Given this list of marker genes PSMF1, SMG1P3, AFF4, RAD17, TTC1, ASXL1, ANKRD40, TACO1, DPY19L4, AHCYL2 (adenosylhomocysteinase like 2), ATAD3A, RITA1, COLGALT1, MBD6 (NCBI Gene Id 114785), PCGF3-AS1, KLHL20, AGBL5, TUBA1A, USPL1, ITGB1BP1, TIMM29, ITGA7, CARS2, PTP4A2 (protein tyrosine phosphatase 4A2), PNMA2, ZNF629, SIN3B, TMEM181 (NCBI Gene Id 57583), PRDX1, VPS72, HNRNPK, GSE1, CCNT1, WASF2, ADAM15, FBH1 (NCBI Gene Id 84893), GRK6, LAMTOR5, MYORG, LINC02361, EDC4, KNTC1, PFKL, SCAF1, SENP6, ULBP1, CDC42EP4, CECR2 (NCBI Gene Id 27443), SMARCD2, SNORD54, NSA2, FRA10AC1, ARHGAP28, RPS26, ZFP36, TOB1, ADD2, SMAD2, BLOC1S1, CAP1, MED23, SYCE2, INO80C, B4GALT5, SMIM14-DT, PINX1-DT, CBX2, FZR1, LAMP1, GABARAPL1, C19orf38, GPX1, MCEE, NME1, HNRNPUL1, HUS1, REXO4, POLDIP3, SNHG7, LINC02768, DMAP1, MARK1, KCNIP2, VIM, ATAD2, DDX3X, CATSPERG, MIPEP, RBM28, DENND3-AS1, TM2D1, INVS, ZKSCAN2, SUGCT, TUBA1C, GNAL, CPT1C, MRPS31, OSER1, SNHG22, KCTD9, NOP16, LTBP4, FGD6, TRIP4, IQCH, GATA6, ETV4, WNT10B, ERCC5, TUBB2A, ZFYVE1, GLI3 (NCBI Gene Id 2737), UTP3, LINC02960, DTWD1, TBC1D13, CPOX, STX18, PMP22, NCOA3, GNG12-AS1, CHCT1, SOX8, TTC4, TOP6BL, COMTD1, DYNC2I2, TRDMT1, ZFP28, CMSS1, KCTD5, VMAC, PPP1R35, CDK4, CEP112 (NCBI Gene Id 201134), PBX3, NFE2L1-DT, PDCD6-DT, MZT2B, BHLHE40, RACGAP1, CCNI, EXD2, NOL9, EIF4A3 (NCBI Gene Id 9775), KLC1, ASAP3, HEATR5A-DT, SAE1, SLC25A6, SNORA16A, TMED1, RANBP1, KCTD7, CEP120, CIC, AP3M2, HNRNPD-DT, CD2AP-DT, PAFAH2, ALDOA, ACOX1, ENO3, FEM1B, MALAT1, NSL1, PPP2R5B, KANSL3, VDAC3, MRPL39, LMNB1-DT, CLIC4, MZT2A, STAT6 (signal transducer and activator of transcription 6), TYMS, KIAA1586, BRF2, GANC, GNAI3, AP4M1, STARD3NL, ZMIZ1-AS1, HSPE1, ASH2L, WIZ, BRD2, SPTAN1, CTNNB1, FAAP20, CFL1, VPS25, RPL41, RPL37A, DST-AS1, PSMD9, MACIR, GSPT1, RNF32, RPL37, IMMT, MAP3K14-AS1 (MAP3K14 antisense RNA 1), PRKAA1, GEMIN5, COX16, MRPL16, AK6, RBSN, FXYD5, SEC31A, CCDC88A, UBE2L3, RPL29 (ribosomal protein L29), DPP8, PHF12, GAS5, ZNF892 (zinc finger protein 892), GSX1, NUP155, SDHAF3, BECN1, HM13, SNAP29, CDCA2, CPSF3, RETREG2, USP30, ZNF165, FAM200B, RPLP2, SPATA33, CHFR-DT, SOS1, ATP6V1G2, RABGEF1, NAA80, RHOC, DNAJC25-GNG10, UQCC6, MAP3K21, LRP6, RAC1, POLR3H, TRIM46, AMN1 (NCBI Gene Id 196394), MPHOSPH10 (NCBI Gene Id 10199), TAGLN2 (NCBI Gene Id 8407), PDXK, S100A4, EFNB3, MTND5P11, ABCC10, HEXIM2-AS1, GPRC5A, ATG13, PLD6, ZNF839, SLC27A4, KMT2A, NFE2L1, SERTAD3-AS1, GGNBP2, CALM2, NEURL2, LINC01275, LINC01547, GTF2H4, LINC00431, ERP44, GSTCD, USP32, TAS1R1, DDX46, LINC00662, FAM241B, ARPP19 (cAMP regulated phosphoprotein 19), PRPH, ICE1 (NCBI Gene Id 23379), IRF9, WDR13, GNB2, DST, YIPF2 (NCBI Gene Id 78992), SLC15A4, MAD2L2, GOLT1B, CNPPD1, CEROX1, TMEM104, C6orf141, TOB1-AS1, ZFP30, ANKRD28, ZNF213-AS1, BRMS1L, ZNF609, RECQL, KRT8, EML2, CDC42, TATDN3, FAAH, PIF1, EXOC2, SMG7-AS1, AJUBA-DT, AJUBA, STAT3, DCTN6, TNNT1, UBC, DDX54, ZMYM1, POLK, CCDC77, MTMR9, CTSA, MARCHF6, EFCAB14, PPP1R12A, RGS5, IL12A, ZNF205, ARHGAP45, LOH12CR2, APOM (apolipoprotein M), PHF5A, CDC42SE1, RNF32-DT, SCAP, TAMM41, HOXB3, GINS3, UBE2A, PICALM, PDCD6IP, THUMPD3-AS1, LRRFIP2, MAN2C1, STX16-NPEPL1, RUVBL1, RNU12, BBX, BMS1P4-AGAP5, ERBB3, DYNLT1, ATP5PD, ZFP28-DT, H2AC25, PAFAH1B2, MYL6, ZNF503, MECR, NDUFS3, MLH1, CELSR1, PI4KA, S100A2, RSRC2, TCTA, CERNA3, ATRIP, LINC02987, SYT7, USP45, MCF2L, TCF3, CCNL1, POFUT2, MTA2, KMT2D, MTHFD1, ACAA2, CACTIN, NUP62, FAM83E, EIF1 (eukaryotic translation initiation factor 1), PPP2CB, WEE2-AS1, ZNF585B, ZNF561, MIR4453HG, PKMYT1, YIF1B, SLC25A45, TLE2, PLEKHM1, C1orf159, ZNF391 (zinc finger protein 391), DCTN6-DT, FAM227B, PPP1R3E, FNTA, HCFC2, MICU1, UBE2Z, USP31, SGMS1, PEMT, CIMAP3, BCAT2, KBTBD4, MOB3A, IER5L-AS1, MIR6781, DCP1A, CREBL2, MRPL40, MRPL27, INTS14, WDR24, C17orf75, AGBL5-AS1, PLEKHG4B, KCTD10 (potassium channel tetramerization domain containing 10), DDX1, PIM1, RP2, SELENOH, ACO2, NUF2, SYNPO2, OTUD7B, RMI2, STX16, ANO8, SLBP, EPCIP-AS1, HSPE1-MOB4, CHRNB1, SSBP1, PDCD6, URM1, SDE2, RCOR1, SLC33A1, WDR11-DT, MTF2, ZNF354A, SPACA9, ENSG00000261398 (NCBI Gene Id 112268173), BANF1, RTN4, CCDC97, ZNF233, NDUFA11 (NCBI Gene Id 126328), LMF1, PEF1-AS1, PNPLA7, NAGK, SAMD4B, PIK3R1, DNAH2, GUSB, GABPB2, JPX, STARD4, ANKRD16, PRELID2, ZMYM6, DAB2IP, GOLM2, TRIM37, AFF4-DT, MRPL48, ZMPSTE24, MET, LARGE1, LMF2 (NCBI Gene Id 91289), SF3A3, RPS8, CA5BP1, NMNAT1, ENSG00000247416, RPL22, CAST, GOLGA3, ZNF503-AS2 (ZNF503 antisense RNA 2), MARCHF6-DT, KDM5C, DYRK1B, SMPD4, LRRC59, RHOA, PINX1, MC1R, WDR11, PANX1, LINC01409, ANP32B, TPT1-AS1, SCAPER, SERTAD3, FAR1, C12orf75, HARBI1, SNORD55, SMG8, MMUT, CLPTM1, KAT6B, BUD31, METTL2B, ST13, UBE2H, IZUMO4, RAD52, CPPED1, PPP1R18, ZNF561-AS1, CD2AP (NCBI Gene Id 25916), TMEM41A, CASC3, SLC25A53, ARL6IP1, ATP5MF-PTCD1, SELENOW, LINC02352, GBA1, CD9, TLCD3B, RPL38, PIPOX, SPRY4, DUS1L, VEZT, PKP2, RPL27, PDCD6P1, LZIC, PFN1, DLEU1, LGALS1, NDUFS7, PTGES3, TMEM87A, MBD2, RAB11A, SLC36A1 (solute carrier family 36 member 1), BPTF, NFKBIL1, ZNF76, SNRPE, DISC1, RPL37A-DT, ZNF581, HEXIM2, RPS20 (NCBI Gene Id 6224), RPS14, ZNF793, NOXA1, HSPB6, SH2B3 (SH2B adaptor protein 3), TAF3, CTNNA1, SVIL, DENR, CAPNS1, KDM5A, ADGRE5, SND1, CYP1A1, GLT8D2, SNHG11, INTS12, SYNC, PPT1, UCKL1, CEBPA, NME1-NME2, LRRC57, CSNK1D, SLC24A1, NHP2, INO80B, TRAF4, AGGF1, C1QL4 (NCBI Gene Id 338761), ZER1, HBS1L, GATA6-AS1, GABBR1, WDR31, MICAL3, PHF20, EIF2S3, XKR6, KCNH2, TPT1, SYK, SUZ12P1, EXD3, HYAL3, PPP2R3C, TMEM242, VARS1, FBXL5, VARS2, UBB, CSTPP1, ATF5, CDIP1, LRFN4, INO80B-WBP1, RRAGC-DT, DNAJC25, PPP1R14C, BBS1 (Bardet-Biedl syndrome 1), TMEM200B, CD2BP2, RBPJ, GINS1, ZNF181, TNFAIP8, FAM168A, MRPS31P5, NR2F1, PLIN3, DCLK1, ZBTB37, KLHDC9 (NCBI Gene Id 126823), COQ8B, DENND3, EXOSC3, RRP15, SNHG12, ZCCHC2, PBX3-DT, CERT1, AGA, SMG7, ATXN2L, C12orf76, SLC41A2, PCLAF, LNP1, CCNDBP1, PTPN21, WDR43, BIRC5, SLC39A3, MNT (NCBI Gene Id 4335), SH2D3A, TMEM222, RBAKDN, TBRG4, NCAPH2, NR2F6, MRPS31P4, GFM2, KPNB1, MAP2K2, DRG2, ADAP2, DPCD, DHDDS, PSIP1, AAGAB, TTC33, IPO4, EME1, CNIH3, KRTCAP2, PTPN18, CFAP298, PAK1IP1, CHFR, SMIM14, YJU2, BORCS5, SRCIN1, SVIL-AS1, RNU7-27P, KCNJ4, MIB2, BEND6, RPS7, UBE2H-DT, SNHG17, TJP3, PROSER3, ZC3H4, CENPO, MCM7, OSER1-DT, LINC02026, TRIB1, MRPL44, CASZ1 (castor zinc finger 1), CAV1, ZNF570, SOCS1, MCAM (NCBI Gene Id 4162), FBXO5, TRABD, CFAP298-TCP10L, LAMTOR5-AS1, CPEB4, PDAP1, USE1 (NCBI Gene Id 55850), PTMS, NEIL1, KRAS, SETD4, RNF43, TRMT2A, TBC1D19, KIFBP, TNK2-AS1, GLUD1P3, MARCHF8, ACADSB, GTPBP3, VGLL4, HNRNPL, IQGAP3, PCID2, PRORP, NBPF19 (NCBI Gene Id 101060226), ZNF793-AS1, HMGB1, NDUFB7, INKA2, UBE3B, METTL15, IL4I1, DPYSL2, NPHS1, MPLKIP, LTA4H, ZNF621, ACTG1, AAAS, PIWIL4, MIR5188, RABAC1, ZNF217, WDR76, CACNB1, MTCO3P12, SRSF1, CHMP3, EIF1AD, CBX4, HSPD1, POLR3B, NDUFV2-AS1, TAF9, RAD51, SLX9, TOB2 (NCBI Gene Id 51445), OGG1, PEPD, CENPJ, CCNT2-AS1, SFSWAP, ETV2, SCARNA17, PPCDC, GABARAP, PTCD1, CEBPG, VTN, GFI1B, CCT8, FBXW8, CUL4A, NRAS, MIB1, ENSG00000259881, FBXW7, NFATC4, PTRHD1, ZNF335, VSIG10, SEC13, ZCCHC24, ANKRD12, UBTD2, SCFD1, NKAPD1, TMEM242-DT, PEF1, LINC01144, BRPF1, PPP2CA-DT, CENPQ, PPP2CA, HAUS2, CHMP1A (charged multivesicular body protein 1A), RDX, DLK2, HTATSF1P2, UBE2S (ubiquitin conjugating enzyme E2 S), ZMPSTE24-DT, BNIP2, PRKAB2, SNIP1, ZBTB45, GTF3C5, PDE6D, COPS7A, ADAT2, UNC13B, HEATR5A, ETS2, SETD5, NDUFAF6, DPP9, ENSG00000232995, TMSB10 (NCBI Gene Id 9168), COPS5 (NCBI Gene Id 10987), PSD2-AS1, ATP5MF, TEFM, CDIPTOSP, RNF38, CLUAP1, WEE1, PIDD1, YWHAB, BMS1P4, AVPI1, TPK1, GEMIN8, WDR36, VPS51, WTAP, STX11, PPP2R1A, YKT6, ERLIN2, CCNT2, PAXBP1, TOP3B, RFX2, COL1A1, MYL6B-AS1, PUF60, LSG1, EXOSC10, UBA52 (ubiquitin A-52 residue ribosomal protein fusion product 1), APOOL, C6orf52, TBC1D15, ZBTB40, LMNB1, ENPP3, MIR5695, TMEM102, LINC01237, CBR3-AS1, PISD, EGLN2, POMT1, MIR548AW (microRNA 548aw), RNF213-AS1, MARS1, SPRED2, ENSG00000263080, GARRE1, KDM3A, KPNB1-DT, MRPL41, STX18-AS1, IKZF5, RBFOX2, MIR615, MAZ (MYC associated zinc finger protein), PCSK1N, RBM3, PEX3, HIRA, LINC01775, PRPSAP1, RSRP1, PPP3CB-AS1, RRAGC, ENSG00000263280, NCAM1, EPM2AIP1, BRWD1, PIH1D2, GALNT16-AS1, RMI1 (NCBI Gene Id 80010), CASC9, XPNPEP3, TMBIM6, WASHC2A, NEBL, TSC1, SPRY4-AS1, LYPD5, GNE, PARP4, CCNE1, PPP2R2A, GATAD2B, LRRC1, MIR4530, ATP6V1G2-DDX39B, STMN3, CLTC, BAG6, CNOT4, ZNF133, MTHFD1L, CHEK1, AP1G2, FAM21EP, HNRNPD, LRRC37A5P, CDIPT, ZNF569, COASY, TSC22D4, PWP1, KATNAL1, PPID, SEMA6A, CRBN, RAD51-AS1, RIF1, VIM-AS1, CTNNA1-AS1, ADD3 (adducin 3), COPS7B, CDHR2, LSR, GASAL1, ENDOV, CSPP1 (centrosome and spindle pole associated protein 1), ENSG00000232876, MRPL28, NAT9, MTF1, here is a description of the gene set: species: Homo sapiens from publication Yevshin I, Sharipov R, Kolmykov S, Kondrakhin Y, Kolpakov F (PMID 30445619) Genes containing one or more binding sites for (KLF7) in their promoter regions (TSS -1000,+100 bp) as identified by GTRD version 20.06 ChIP-seq harmonization. Human Gene Set: KLF7_TARGET_GENES